The following is a description of a gene set: from publication Yevshin I, Sharipov R, Kolmykov S, Kondrakhin Y, Kolpakov F (PMID 30445619) Human Gene Set: F2RL1_TARGET_GENES Genes containing one or more binding sites for (F2RL1) in their promoter regions (TSS -1000,+100 bp) as identified by GTRD version 20.06 ChIP-seq harmonization. studied in species Homo sapiens, and this is the list of marker genes: MT-TS2, MT-TL2, MTCO3P12, MT-TH, MTND5P11